The following is a description of a gene set: Human Gene Set: GSE22935_UNSTIM_VS_48H_MBOVIS_BCG_STIM_MYD88_KO_MACROPHAGE_DN studied in species Homo sapiens from publication Qualls JE, Neale G, Smith AM, Koo MS, DeFreitas AA, Zhang H, Kaplan G, Watowich SS, Murray PJ (PMID 20716764) Genes down-regulated macrophages with MYD88 knockout: untreated versus 48h after M. bovis BCG infection. Nitric oxide (NO) produced by macrophages (MØs) is toxic to both host tissues and invading pathogens and its regulation is therefore essential to suppress host cytotoxicity. MØ arginase 1 (Arg1) inhibits NO production by competing with NO synthases for arginine, the common substrate of NO synthases and arginases. Two signal transduction pathways control Arg1 expression in MØs. First, a MyD88-dependent pathway induces Arg1 in intracellular infections, while a second Stat6-dependent pathway is required for Arg1 expression in alternativelyactivated MØs. We found that mycobacteria-infected MØs produce soluble factors that induce Arg1 in an autocrine-paracrine manner via Stat3. We identify these factors as IL-6, IL-10 and GCSF. We further establish that Arg1 expression is controlled by the MyD88-dependent production of IL-6, IL-10 and G-CSF rather than cell intrinsic MyD88 signaling to Arg1. Our data reveal the MyD88-dependent pathway of Arg1induction following BCG infection requires Stat3 activation and may result in the development of an immunosuppressive niche in granulomas due to the induced Arg1 production in surrounding uninfected MØs, and this is the list of marker genes: EPHX4, PIGP, SUMF2, GLO1, PPP1R3G, ZC2HC1A, RBP4, C4orf19, PRR22, RSL1D1 (NCBI Gene Id 26156), P2RX4, GUCY1A1, PPP2R5C, SPAG4, LGALSL, EQTN, GPRC6A, EXO5, CARD19, TRMT1, PDE6G, LMNTD2, GFPT2, SPACA4, ADAMTSL1, ANKRD2, RGS10, HAPLN2, POU3F4 (NCBI Gene Id 5456), NOS3 (nitric oxide synthase 3), CCL2 (C-C motif chemokine ligand 2), NECTIN2, GLIPR1L1, SHROOM3, SAP18, YJEFN3, B3GALT6, SRFBP1, NLRP5, TNNT1, GIMAP1, FGF20, ADCY4, PLEKHA7, P2RX7, CFL2, RPAP1, CD84 (NCBI Gene Id 8832), ATP5PF, CADPS2, ARHGEF15, TRARG1, PLA2G2A, NUDT12, SEL1L2, ACSF2 (NCBI Gene Id 80221), SH3GL3, PHLDA1, SDHAF1, CD3G, HIC1, ZNF827, LCN9, MYO7A, TPD52L1, ADAM19, PYROXD1, NEUROD1 (NCBI Gene Id 7853), GPR12, CLXN, NOTUM, GABRA3, RPF1, SIRT4, CHI3L1, SIRT6, JMJD8, IL1F10, TECR, CBLN4, SPRN, GABARAPL1, ENSG00000285566, NAAA, DRAM2, CIDEA, IGDCC3, TIMMDC1, PRELID1 (PRELI domain containing 1), FHIP1B, PCDHA11, NAA35, VASN, MCTP1 (NCBI Gene Id 79772), PEX14, DMD, CXorf49B, SEMA4C, SBDS, PGAM2, NDUFA6, MMD, PDE1A, ETF1, CREB3L3, BTF3, ZNF688, IRAG2 (inositol 1,4,5-triphosphate receptor associated 2), PAIP2, TMBIM4, LONRF2, DPYSL3, CLDN11, C3orf22, CYP4A22, TERB2, OSBPL10, CCL24, KRT79, THG1L, GATA3, SMYD2, CHODL, SLC22A6, LRFN3, MXD4, EGFL8, ACAA2, DOCK3 (dedicator of cytokinesis 3), CENPB, PLXNA3, OR7C1, DGAT1, ANXA5 (NCBI Gene Id 308), CD38, ZAN, TREX2, AUH, UNC119, FFAR2, CYP2W1, NDUFA10, ARRDC4, PRRT4, TBC1D4, CAPN3, VSTM5, IRF5, PRR16, CDH6, CHURC1, HDAC10, NAV2, KLF9, GRM1, TNFSF11, TRMO, ANGPTL7, SNX31, KDF1, SLC6A18, HNRNPA0, EEIG2, UBQLN3, TMEM176B, MECOM, HNRNPLL, TNK2, NKX6-2, WDR70 (NCBI Gene Id 55100), TMEM273, ENG, GRIK3, RASL11A, HPDL, CCBE1, MYH11, HOXA2, DYNC2I1, SST, FGL1, CSRP3, NIPSNAP1, CABS1, SYT2, SEPTIN3, EGR4, TGM5, IZUMO1R, SERPINA11, BARHL2, OPRM1, LYRM4, SMIM7, IGSF11 (NCBI Gene Id 152404), FAHD2A, LYRM1, KLHDC8A, SYNE4, DYNLRB1